Given this list of marker genes Wdfy3, Atg12, Atg16l1, Atg16l2, Atg3, Atg5, here is a description of the gene set: A protein complex required for the expansion of the autophagosomal membrane. In budding yeast, this complex consists of Atg12p, Atg5p and Atg16p. Mouse Gene Set: GOCC_ATG12_ATG5_ATG16_COMPLEX species: Mus musculus